The following is a description of a gene set: Mouse Gene Set: GOBP_CELLULAR_RESPONSE_TO_LUTEINIZING_HORMONE_STIMULUS species: Mus musculus Any process that results in a change in state or activity of a cell (in terms of movement, secretion, enzyme production, gene expression, etc.) as a result of a luteinizing hormone stimulus., and this is the list of marker genes: Edn1, Ccna2 (cyclin A2), Ednra, Lhcgr, Star, Cyp1b1